Given this list of marker genes Atg3, Eloc, Sel1l, Plaa, Fam8a1, Cul2, Hdac6, Elobl, Neurl2, Elob, Vhl, Syvn1, Rbx1, Vcp, here is a description of the gene set: Mouse Gene Set: GOCC_CYTOPLASMIC_UBIQUITIN_LIGASE_COMPLEX A ubiquitin ligase complex found in the cytoplasm. species: Mus musculus